The following is a description of a gene set: Mouse Gene Set: GOMF_ALL_TRANS_RETINYL_PALMITATE_HYDROLASE_ALL_TRANS_RETINOL_FORMING_ACTIVITY studied in species Mus musculus Catalysis of the reaction: all-trans-retinyl palmitate + H2O = all-trans-retinol + H+ + palmitate., and this is the list of marker genes: Ces1d, Ces2a, Lipe, Ces1e, Ces1f, Ces2e, Ces2c, Pnlip